The following is a description of a gene set: studied in species Mus musculus The progression of the neural retina over time from its initial formation to the mature structure. The neural retina is the part of the retina that contains neurons and photoreceptor cells. Mouse Gene Set: GOBP_NEURAL_RETINA_DEVELOPMENT, and this is the list of marker genes: Calb1, Mir96, Megf11 (multiple EGF-like-domains 11), Samd11, Thy1, Barhl2, Fos, Rho, Rpgrip1, Naglu, Ndp, Rp1, Trpm1, Ihh, Mir124a-1, Foxn4, Ahi1, Ttc8, Rom1, Slc1a1, Atp2b4, Hes1, Dlx1 (NCBI Gene Id 13390), Sdk1, Cfh, Dll4, Dlx2, Pou4f2, Gpm6a, Neurod1, Rdh13, Gdf11, Ptn, Crb1, Irx6, Bsg, Vsx1, Dio3, Atoh7 (NCBI Gene Id 53404), Sox8, Fjx1, Gnat1, Gnat2, Mir183, Tgif1, Per1, Ikzf1, Tgif2, Large1, Miat, Samd7, Tgfb2, Hipk1, Tfap2b, Psen1, Ush1c, Mir124a-2, Lhx1 (NCBI Gene Id 16869), Slc17a8, Rorb, Ptf1a, Bhlhe23, Neurod4, Casp2, Zhx2, Stat3, Sdk2, Nrl, Sox9, Dscam, Prdm1, Prom1, Actl6a, Arl6, Cabp4, Rpgrip1l, Casz1, Atp8a2, Vax2os, Bbs10, Ntrk2, Tspan12, Pde6c, Cntf, Hcn1, Crb2, Rpe65, Thrb, Slc4a7, Smarcd3, Fat3, Bbs4, Cnga3, Six3, Bhlhe22, Irx5, Vsx2, Notch1, Ptprm, Alms1, Hipk2, Usp45, Rs1, Mir182